The following is a description of a gene set: studied in species Homo sapiens Human Gene Set: GSE2706_R848_VS_LPS_2H_STIM_DC_UP from publication Napolitani G, Rinaldi A, Bertoni F, Sallusto F, Lanzavecchia A (PMID 15995707) Genes up-regulated in comparison of dendritic cells (DC) stimulated with R848 at 2 h versus DCs stimulated with LPS (TLR4 agonist) for 2 h. Toll like receptors (TLRs) sense microbial products and initiate adaptive immune responses by activating dendritic cells (DCs). Since pathogens may contain several agonists we asked whether different TLRs may synergize in DC activation. We report that in human and mouse DC TLR3 or TLR4 potently synergize with TLR7, TLR8 or TLR9 in the induction of selected cytokine genes. Upon synergistic stimulation, IL-12, IL-23 and Delta-4 are induced at levels 50-100 fold higher than those induced by optimal concentrations of single agonists, leading to enhanced and sustained TH1 polarizing capacity. Using microarray analysis we show that only 1.5% of the transcripts induced by single TLR agonists are synergistically regulated by combinations of TLR4 and TLR8 agonists. These results identify a combinatorial code by which DCs discriminate pathogens and provide (suggest) a rationale to design adjuvants for TH1 responses. Series_overall_design: 3 untreated, 3 treated with LPS at 2h, 3 treated with LPS at 8h, 3 treated with R848 at 2h, 3 treated with R848 at 8h, 3 treated with LPS + R848 at 2h, 3 treated with LPS + R848 at 8h, and this is the list of marker genes: RLN3, TLCD1, EPCIP, SMAD1, STK17B, S1PR3, NT5DC3 (NCBI Gene Id 51559), ATP4B, MGAT3, TMEM243, IQCF2, ASCL2, CYP1A1, PCDHGC3, XKR6, DDX51, GLI2, SLC38A4-AS1, RHEX, ZNF23, PLAGL2, LILRA3, ZNF324, HOXA11-AS, LILRA5, TJP1, ENSG00000269210, TJP2, CFC1B, FAT2, ALDOAP2, TAS2R50, VNN2, CLGN, CDCA4, STRC, PRELP, ZNF791, SLC35F1, LINC01106, CD300LG, TCF7L2, C8orf34-AS1, TICAM1, SERPINB12, FAM167A-AS1, MMP3, SOX9, CR1L, ZKSCAN5, LILRB2, MGC27382, GOLGA2P5, IGFN1, ADTRP, CFAP210, HS6ST3, GNAT2, TEDC2, LSM11, SNX32, OR8B8, TUBB2A, MYT1L, POLR2M, CFAP95, FAM47B, RGS13, CTCFL, PHGR1, EPHA1, KIF1A, SLC2A3, LINC03006, H2AC13, EML5 (EMAP like 5), LINC01012, PHETA2, C3P1, CHIC1 (cysteine rich hydrophobic domain 1), NPFF, NEK2, ITPKC, MYH7B, SLC35F5, ATP6V0A4, PJA1, ZNF134, RPUSD2, FLACC1, DKK2, CLDN10, SMG6, RSPH1, LINC00102, CLDN1, ZNF701, BTBD8, LINC02297, ATP1B2, HINFP, ZNF836, CCER1, IGSF21 (immunoglobin superfamily member 21), ZNF671, PCYT1B, NAT8 (NCBI Gene Id 9027), PRKCZ, EFNB2, GAMT, MTRFR, ARF6, AQP11, EGFL7, AMPH, TRIM36, DSCR10, LEMD1, CSRNP2, PHLDB2, ROBO1, SHISA6, IGFBP1, MYEOV, FGF7, RAI14, FOLH1B, PDCD7, NPHP1, TAGAP, GOLGA7B, SPATA3-AS1, ASTN2, LRTM2, GABRG2, CYP27B1, LINC00663, CCN4, GPR19, GPRC6A, TSPAN12, DLEU2 (deleted in lymphocytic leukemia 2), LINC00472, CACNG1, CST5, KIT, ZIC1, LINC00482, REXO1, PCSK9, CASC11, RHBDF2, TAS2R1, CPN2, CHEK1, CHST2, CYMP-AS1, RAB3IP, SP3P, CLTCL1, SP2-AS1, HMGN2P46, CHST7, MGAM, IRX5, IL27RA, LINC01622 (long intergenic non-protein coding RNA 1622), POU3F2, ZNF574, FDPSP2, BBS12, MACROD2, PRDM13, CCNB2, RTP5 (NCBI Gene Id 285093), THEMIS2, ZNF597, TMEM30B, IQCK, ZNF777, LLGL2, CBX3P2, CCL2, ZNF708, PWRN2, AREG, GHRH, SIGLEC11, ZNF441, NPHP4